Given this list of marker genes NDE1, TUBB4A, ARHGEF7, MAP7D3, PSRC1, TRPV4, MAPRE1, NAV3, TOGARAM1, CDK5RAP2, HAUS6, HAUS5, TBCD, OCLN, TUBGCP5, PDE4DIP, MAP2, TUBGCP4, FGF13, SLC39A12, DRG1, HSPA1A, CCDC57, GOLGA2, NEDD1, NIN, BLOC1S2, CAMSAP3, CAMSAP2, TUBGCP2, CDH5, PRUNE1, HAUS2, HAUS7, TPPP2, TUBB1, HAUS3, CLIP1, CLASP1, NME7, CLASP2, PPP2CA, TUBA1A, STMN2, MAP1B, SKA1, TPPP3 (tubulin polymerization promoting protein family member 3), SSNA1, DYRK1A, INPP5J, DCTN1, ARL2, HAUS4, AKAP9, HAUS8, EML2 (NCBI Gene Id 24139), DIAPH3, CEP192, MAP4, CLIP3, HAUS1, TPX2, GBA2, CAMSAP1, NDEL1, FKBP4, CCDC66, CKAP5, HSPA1B, FES, TUBGCP3 (NCBI Gene Id 10426), MECP2, PAK1, MZT1, RANBP9, PIN1, SNCA, TUBGCP6, RPS3, KIF21A, SLAIN1, CDK5R1, CSNK1D (NCBI Gene Id 1453), ZNF207, CDKN1B, ABL1, FBXO5, ANKRD53, HDGFL3, NUMA1, STMN1, PPP2CB, TUBG2, TUBG1, SLAIN2, PCNT, CENPJ, CAV3, GIT1, MAPRE3, MAPT, RAC1, MET, TPPP, here is a description of the gene set: Human Gene Set: GOBP_MICROTUBULE_POLYMERIZATION species: Homo sapiens The addition of tubulin heterodimers to one or both ends of a microtubule.